Given this list of marker genes ASH1L, SPAG9, PAXBP1, SLK, NOP14, ENAH, ZMYM4, SYNE2, SETD2, KCNQ1OT1, H1-4, PCM1, KMT2A, H2AC20, MACF1, SMC1A, TRIP11, SUZ12, SENP6, GOLIM4, TASOR2, H1-5, CLINT1 (NCBI Gene Id 9685), UACA, ZNF638, CEP350, BDP1, AHCTF1, ARGLU1, SMCHD1, BAZ1B, ATAD2, MSH6, RIF1, GOLGA4, NRDC, MT-ND6, PTPN11 (NCBI Gene Id 84990), TRIM44, SMC5, SMARCA5, TJP1, PHF3, ROCK2, DST, GOLGB1, H1-2, SPEN, ATAD5, RANBP2, here is a description of the gene set: from publication Gavish A, Tyler M, Greenwald AC, Hoefflin R, Simkin D, Tschernichovsky R, Galili Darnell N, Somech E, Barbolin C, Antman T, Kovarsky D, Barrett T, Gonzalez Castro LN, Halder D, Chanoch-Myers R, Laffy J, Mints M, Wider A, Tal R, Spitzer A, Hara T, Raitses-Gurevich M, Stossel C, Golan T, Tirosh A, Suvà ML, Puram SV, Tirosh I (PMID 37258682) Genes upregulated in subsets of cells of a given type within various tumors studied in species Homo sapiens In this study, an extensive analysis was conducted to define meta-programs (MPs) capturing intra-tumor heterogeneity across a spectrum of tumor types. The approach utilized non-negative matrix factorization (NMF) to analyze each cell type separately within individual tumor samples. This involved the analysis of malignant cells, macrophages, fibroblasts, endothelial cells, epithelial cells, T-cells, and B-cells. NMF was executed with varying parameter values (K=4, 5, 6, 7, 8, 9), thereby generating 39 programs for each cell type per sample. Each NMF program was summarized by the top genes based on NMF coefficients.\nRobust MPs were then delineated for each cell type using a set of stringent criteria, including recurrence within the same tumor, similarity to programs in other tumors, and non-redundancy within a tumor. Subsequently, these robust NMF programs were clustered (per cell type) based on Jaccard similarity, leading to the identification of MPs associated with each cell type.\nTo enhance the quality of the MPs, a refinement steps were undertaken, involving the removal of MPs suspected of reflecting low-quality data (with an overrepresentation of ribosomal proteins or mitochondrial-encoded genes), single-study inclusion, or similarity to miss-annotated cell types. Human Gene Set: GAVISH_3CA_MALIGNANT_METAPROGRAM_4_CHROMATIN